Given this list of marker genes RPIA, here is a description of the gene set: part of: Pentose phosphate pathway disease Reactome Pathway: RPIA deficiency: failed conversion of R5P to RU5P species: Homo sapiens A mutation in ribose-5-phosphate isomerase (RPIA), an enzyme of the pentose phosphate pathway that normally mediates the reversible interconversion of ribose 5-phosphate and D-ribulose 5-phosphate, has been associated with a slowly progressive leukoencephalopathy.